The following is a description of a gene set: Genes down-regulated in macrophages: untreated versus 48h after M. bovis BCG infection. Human Gene Set: GSE22935_UNSTIM_VS_48H_MBOVIS_BCG_STIM_MACROPHAGE_DN from publication Qualls JE, Neale G, Smith AM, Koo MS, DeFreitas AA, Zhang H, Kaplan G, Watowich SS, Murray PJ (PMID 20716764) species: Homo sapiens Nitric oxide (NO) produced by macrophages (MØs) is toxic to both host tissues and invading pathogens and its regulation is therefore essential to suppress host cytotoxicity. MØ arginase 1 (Arg1) inhibits NO production by competing with NO synthases for arginine, the common substrate of NO synthases and arginases. Two signal transduction pathways control Arg1 expression in MØs. First, a MyD88-dependent pathway induces Arg1 in intracellular infections, while a second Stat6-dependent pathway is required for Arg1 expression in alternativelyactivated MØs. We found that mycobacteria-infected MØs produce soluble factors that induce Arg1 in an autocrine-paracrine manner via Stat3. We identify these factors as IL-6, IL-10 and GCSF. We further establish that Arg1 expression is controlled by the MyD88-dependent production of IL-6, IL-10 and G-CSF rather than cell intrinsic MyD88 signaling to Arg1. Our data reveal the MyD88-dependent pathway of Arg1induction following BCG infection requires Stat3 activation and may result in the development of an immunosuppressive niche in granulomas due to the induced Arg1 production in surrounding uninfected MØs, and this is the list of marker genes: CNTN6, WARS1, OTX2, CD2, RUNX3, RHOG, GPR65, LRRC58, TRAF4, BLCAP, ERAS, ITPRIP, SLC1A7, TAGLN, SNX5, BPIFA1, DCLK2, P2RX1, ECM1, MACIR, REL, BEND5, TPSG1, SPG7, MGAT4B, ENG, UBC, DSP, ARHGAP17, CPNE3 (copine 3), ASAP2, TSTD2, INTS1, GDF2, FGFR1, CC2D1B, MXD1, CBLN2 (cerebellin 2 precursor), ETV5, FLVCR1, VPS4A, POGZ, RNASE6, IL6R, PROCR, NRSN2, PIK3CB, STK38L, CBX4, MIR22HG, LTA, STARD10, GPR15, TSC22D2, TBCCD1, MIOX, SCIN, LRIG1, ZUP1, PPM1L, KIF5B, L1CAM, OSBPL5, FAM120A, PDZRN3, ARHGAP10, DYRK1A, FOXRED1, COG5, SPTAN1, SIX5, MAPDA, YPEL2, BAIAP3, LGMN, IL22, KIAA0232, OTULIN, RNF112, CAPN10, RAB3IP, C19orf38, BBS2, MAGED1, VAC14, CSRNP2, SPAG16, CITED4, STX1A, LRP5, C19orf47, CACNB4, ETV6, RPL10, CTSS, SIK2, ZNF347, DR1, ADGRB1, CD247, HNRNPF, CRIP1, MARCHF7, ABCG1, ZBTB17, DIAPH2, RGMB, PRKAB1, B3GNT5 (UDP-GlcNAc:betaGal beta-1,3-N-acetylglucosaminyltransferase 5), SMR3A, DSE, SLC26A10P, INF2, C10orf90, SHISAL2B, MAP2K4, POM121L12, HSPBAP1, IL1R2, TRIM59, ACTR1A, CRHR2, THBS1, PAG1, FBXO7, COL9A3, STK19 (NCBI Gene Id 8859), HPS5, TSGA10, GSTO1, RRAGD, CFAP300, CD74, GFPT1, C16orf89, SH3RF3, LETM1, GPATCH3, CPEB2, RPS16 (NCBI Gene Id 6217), GPR35, CTSG, KCTD12, RCBTB1, NIPA2, TAL1, PINX1, NRP2, SHC1, IBTK, SPSB3, STK16, KIAA1191, PTGFRN, LAMP2, CSAD, ATP6V0D1, C16orf95, MTFP1, WRN, TGIF1 (NCBI Gene Id 91941), KIT, IQCB1 (NCBI Gene Id 9657), NMI, ZFYVE26, NCKAP1, KATNA1, EIF4G2, SLC37A2, RND2, GBP2, LEMD3 (NCBI Gene Id 23592), ZDHHC24, ARL8B, ILRUN, MOK, RNF24, PTP4A2 (protein tyrosine phosphatase 4A2), SLC35E2B, OSGIN2, LSAMP, YOD1, H3C14, BDKRB1, SRPRB, TMEM140, PDCD2, KIAA1217, SMNDC1, CPA3, PAPSS2, MAPRE2, FRY, ASB13, CECR2, CLOCK, PTCH1, NYX, TPT1